The following is a description of a gene set: species: Mus musculus Mouse Gene Set: GOBP_REGULATION_OF_EPITHELIAL_CELL_APOPTOTIC_PROCESS Any process that modulates the frequency, rate or extent of epithelial cell apoptotic process., and this is the list of marker genes: Tmf1, Umodl1, Nupr1, Prkaa2, Gsn, Hand2, Adar, Trim32, Tcf7l2 (NCBI Gene Id 21416), Naip1, Rb1, Pla2r1, Ppargc1a, Serpinb13, Wnt11, Sfrp4, Igf1, Hdac3, Jak2, Agap2, Btc, Tia1, Mtor, Zfp36l1, Pla2g1b, Npc1 (NCBI Gene Id 98121), Hmox1, Nkx2-6, Pkhd1, Cdkn1b, Sort1, Bok, Pias4, Mdk, Ager, Ppara, Eif2s1, Wfs1, Prkaa1, Atoh1, Sav1, Bad, Neurod1, Bcl2, Yap1, Ttpa, Pgr, Selplg, Esr1, Cast, Nkx2-5, Srsf6, Cflar, Stk4, Atg7, Carm1, Myc, Itgb3bp, Arrb2, Igf1r, Lims1, Spop, Capn10, Gcm2, Alms1, Pdx1, Ngf, Mst1, Apc, Isl1, Zfp36, Bax